The following is a description of a gene set: Any process that results in a change in state or activity of a cell (in terms of movement, secretion, enzyme production, gene expression, etc.) as a result of a lipoprotein particle stimulus. Human Gene Set: GOBP_CELLULAR_RESPONSE_TO_LIPOPROTEIN_PARTICLE_STIMULUS species: Homo sapiens, and this is the list of marker genes: CDH13, SCARB1, ITGB1, ADAM17, APOB, CASR, TXNIP, LPL, SREBF2, MIA3, TLR6, FCER1G, LDLR, AKT1, TLR4, ABCA1, MIR20A, MIR135A1, SYK (NCBI Gene Id 6850), APOE, ABCG1, CD9, SMPD3 (sphingomyelin phosphodiesterase 3), APOA2, MIR146A, ITGB2, CD81, MYD88, TREM2, FUT1, TGFB1, ADTRP, ABCG4, CES1, APOA1, MIR302A, MIR4286 (microRNA 4286), PPARG, MIR92A1, MIR758, SOCS5, NPC1, CD36, CD68, TICAM1, APP